The following is a description of a gene set: Human Gene Set: GOBP_VESICLE_FUSION_TO_PLASMA_MEMBRANE species: Homo sapiens Fusion of the membrane of a vesicle with the plasma membrane, thereby releasing its contents into the extracellular space., and this is the list of marker genes: SYT2, STX2, CPLX4, SNAP29, SNAP47, SYT1, SYT9, RPH3A, ERC2, RAB3A, PRRT2, STX11, RPH3AL, SNAPIN, SYT8, DOC2B, SYT4 (synaptotagmin 4), SYT5, GRIK5 (NCBI Gene Id 2901), SYT7, CPLX2, SYT13, STX19, CPLX1, SNAP23, TRARG1, STXBP1, SNAP25, CPLX3, SYT11, STX1B, DOC2A